Given this list of marker genes FASN, TDRD7, SNORA74A, TPD52L2, PGRMC2, TMEM214, OMA1, PRCC, PTDSS2, PSMC5, PHPT1, IFIT3, HDAC5, HNRNPH3, HERC5, TCF20, NUP35, GSTA4 (glutathione S-transferase alpha 4), EMC9, CD36, H2AZ1 (NCBI Gene Id 3015), SPEF2, TDP1, CDK1, LZTS2, TOMM5, PPP2R5B, TRIM28, LRRC32, SNORA3A, EPM2AIP1, GTPBP6 (GTP binding protein 6 (putative)), ZBTB48, ALDH4A1, GET3, SUCLG1, SLC25A2, IRGQ, SNORA21, MIR128-1, FBXL9P, MIR103A2, DCAF17, PRKCH, TBL3, SNORA75, DNAI4, CACYBP, IPO13, EIF3M, CCL25, RNU12, NOP2, POMT2, SENP8, ING4, GYPC, SLC12A2, FKBP2, SLC16A10, VPS45, CDC34, ACER2, LECT2, NDUFS4, CYB561D2, MIR505, ADH5, ATP5MC3, ABHD8 (NCBI Gene Id 79575), INTS5, MDH2, UTP25, RAB5C, FEM1A, HELZ2, TUBB4B, TRMT1, RPS27A, RPL3, PTK6, WDR13, SNORD73A, ZBTB7B, PCBD2, ATIC, DAZAP1, CAMSAP2 (NCBI Gene Id 23271), PATZ1, LRATD2, BANP, TOPORS, MEX3A, FHOD1, PALB2, SNORA44, ZFP82, NDUFS3, GRPEL1, SNORD95, HDAC9, BLCAP, BUD13, COQ2, ITGA10, KREMEN1, SMAD1, NUDT13, ARL10, GFOD2, RDH10, ANAPC10, USP31, ITGB1BP2, FDFT1, RBM14, SH3GLB2 (SH3 domain containing GRB2 like, endophilin B2), SRP19, H2BC4, CAMKK2, SEPHS2, RBM15B, KIF20B, GPR180, NDUFC2 (NADH:ubiquinone oxidoreductase subunit C2), MX2, DDX24, DFFA, HOMER1, FAM78A, DHX37, ENO1, ISCA2, MEX3C, DLD, PPA1, DCPS, SIPA1L1, CAMLG, STOML2, YTHDF2, FKBP4, GRPEL2 (NCBI Gene Id 134266), SMIM11, NR4A3, SLX1B, PCGF5, TSSC4, DDX18, KLHL2, H2AC6, DAPK1, SLC39A14, SDHAF3, RMDN3, YIF1A, here is a description of the gene set: Genes down-regulated in dendritic cells stimulated by LPS: wildtype versus KDM4D. In dendritic cells, expression of the H3K9me3 demethylase JmjD2d is upregulated by LPS stimulation. To identify genes whose induction by LPS depends on JmjD2d activity, we performed a microarray analysis of wild-type and JmjD2d-knockdown dendritic cells, before and after stimulation with LPS. studied in species Homo sapiens Human Gene Set: GSE32255_WT_VS_JMJD2D_KNOCKDOWN_4H_LPS_STIM_DC_DN from publication Zhu Y, van Essen D, Saccani S (PMID 22633489)